The following is a description of a gene set: Any cellular process that depends upon or alters the intermediate filament cytoskeleton, that part of the cytoskeleton comprising intermediate filaments and their associated proteins. Mouse Gene Set: GOBP_INTERMEDIATE_FILAMENT_BASED_PROCESS species: Mus musculus, and this is the list of marker genes: Shh, Nefh, Krt81, Krt79, Nefm, Mtm1, Krt19, Krt15, Nefl, Krt6a, Krt78, Krt35, Dnajb6, Krt71, Gm5414, Krt77, Krt4, Sync, Krt1, Vps54, Krt34, Krt28, Krt39, Des, Ndel1, Ina, Krt87, Raf1, Pkp2, Plec, Krt83, Krt2, Arhgef28, Flg, Agfg2, Krt12, Gm5478, Krt10, Krt7, Sod1, Csnk1a1, Krt31, Krt27, Dreh, Krt18, Klhl24, Krt25, Macf1, Pkp1, Krt85, Krt13, Nes, Krt6b, Tor1a, Krt26, Krt90, Krt86, Krt16, Fam83h, Krt84, Atf2, Krt33b, Tchh, Evpl, Vim, Krt23, Dst, Krt33a, Krt80, Eppk1, Krt17, Bbln, Krt75, Krt32, Krt76, Krt40, Bfsp2, Krt42, Cln8, Krt14, Synm, Prph, Atp8a2, Atxn3 (NCBI Gene Id 76702), Krt20, Krt36, Krt82, Krt74, Krt24, Krt9, Gfap, Krt73, Ppl, Agfg1, Krt5, Dsp, Bfsp1, Krt72